The following is a description of a gene set: from publication Chen Y, Wang X (PMID 31504780) Genes predicted to be targets of miRBase v22 microRNA hsa-miR-4438 in miRDB v6.0 with MirTarget v4 prediction scores > 80 (high confidence targets). Human Gene Set: MIR4438 studied in species Homo sapiens, and this is the list of marker genes: NDST3, FAM76B, CASTOR3P, GOPC, MRRF, MAP2, DNM3, IDS, MYCN, RAB8B, SLC31A1, LINC03042, TFPI, ZBTB46 (NCBI Gene Id 80337), RIBC1, SENP1, E2F5, MTF2, PRTG, NSUN2, INAFM2, KRT31, TMPRSS11E, MAGI1, CIT, ADAMTS6, EMC6, C17orf75, EPHA5 (EPH receptor A5), EXTL2, RETREG1, IPMK, EIF4G2, ZCCHC2, DNAJC8, SYNCRIP, HECTD2, PLTP (NCBI Gene Id 5360), SRD5A1, AVIL, GYG2, DNAJA2, GDPD1, USP32, PDZD2, NUFIP1, BTG1, ZNF770, NDFIP1, THAP1, ITIH2, LGI2, NRXN1, JPT2 (NCBI Gene Id 90861), ANKIB1, HECW1 (HECT, C2 and WW domain containing E3 ubiquitin protein ligase 1), HOXA5, PABPC5, BEND4, PRIM2, SMG1, USP6, TGFBR1, DMRT1, GSK3B, ZNF519, DCC, EPS15, CCDC186, ATRN